Given this list of marker genes FBN1, VPS9D1, MT-ATP8, HSPA2, VPS37A, UBE2L6, SNAP25, ATP5MC2, MIR4284, TSG101, CFL1, GTF2IRD1, LAT2, NRG1, PRKG1, METTL27, LIMK1, VPS37C, VAMP2, ATPAF1, TRIM50, ULK1, MLXIPL, EIF2A, MYC, MAPK3, CTNNB1, ERCC6, MT-ATP6, ATP5PO, DDX21, RB1, FKBP6 (FKBP prolyl isomerase family member 6 (inactive)), BRD4, RFC2, MVB12A, HDAC2, MYO1C, MIR590, HDAC6, BECN1, OGDH, RFC5, ELN, GAPDH, DEK, HDAC3, SF3B1, STX1A, ACACB, GRIP1, DLD, FAS, GTF2I, ATP5F1D, CLDN5, H2AX, FBLN2, CLASP1, VPS37D, ATF4, UBE2E1, ATP5PB, ATP5F1E, CDKN1C, ATP5F1B, ATPAF2, SQSTM1, SMARCA5, ABHD11, CLDN3, HOXC8, CLDN4, USF1, BAZ1B, GRB2, WNT2, UBIAD1, VPS28, HMGA1, EIF2AK3, DNAJC30, PKLR, BTK, ATP5MC1, CHTF18, UBE2E3 (ubiquitin conjugating enzyme E2 E3), VPS37B, TMEM270, CLIP2, BUD23, CLTC (clathrin heavy chain), ACACA, EIF4H, NUP62, ATP5F1A, TBL2, ATP5MC3, DLST, CLASP2, MYBBP1A, FBLN5, CLDN1, FZD9, PCNA, BCL7B, here is a description of the gene set: Human Gene Set: WP_7Q1123_COPY_NUMBER_VARIATION_SYNDROME 7q11.23 copy number variation syndrome studied in species Homo sapiens